The following is a description of a gene set: studied in species Homo sapiens from publication Chen Y, Wang X (PMID 31504780) Genes predicted to be targets of miRBase v22 microRNA hsa-miR-4724-3p in miRDB v6.0 with MirTarget v4 prediction scores > 80 (high confidence targets). Human Gene Set: MIR4724_3P, and this is the list of marker genes: HACE1, PSIP1, RAPH1, ZNF276, PAQR6, ZNF322, APOLD1, CHCHD7, RBM4, PHF14, SMAD2, BPTF, RPS6KA3, COL6A6, TGOLN2, STAM, SDC2, CMBL, GJA1, PJA2, ZNF800, PAN2, DDAH1 (NCBI Gene Id 23576), VTI1B, DNHD1, ANKRD34C, SIAH1 (NCBI Gene Id 6477), SMAP1 (NCBI Gene Id 648324), RBM27, PDE3A, ZNF124 (NCBI Gene Id 7678), FAM200B, STAG2, ARMC1, SMNDC1, NR3C2, DPM1, CNTN5, NHP2, HLTF, INTS6, PRP4K, LMO7, TECPR2, QKI, SLC25A35, KRAS, C5orf34, SCN3A, COX20, USP44, HIF1A, MSH2, DHFR, KANK2, ONECUT2, GRIK1, MGST2, TET2, LPAR4, EIF3J, AAK1, ARID2, UBE2E3, CADM2 (cell adhesion molecule 2), YES1, TMEM65, MBNL2 (muscleblind like splicing regulator 2), IPO9, CCDC68, BAZ2B, MDGA2 (NCBI Gene Id 161357), CACHD1, STAT1, WWC1, MSL2 (MSL complex subunit 2), STK38L, AVPR1A, EPB41L4B, DACT1, ADAM12